Given this list of marker genes ARRDC1, STAM, SDCBP, ATP9A, ARRDC4, CHMP2A, HGS, SNF8, RAB7A, ATP13A2, CHMP3, TSG101, SMPD3, SDC4, CD34, PRKN, PDCD6IP, SDC1, CHMP6, VPS4A, RAB11A, IFNG, RAB27A, VPS4B, COPS5, here is a description of the gene set: The assembly and secretion a set of components to form an extracellular vesicule, a membrane-bounded vesicle that is released into the extracellular region. Extracellular vesicles include exosomes, microvesicles and apoptotic bodies, based on the mechanism by which they are released from cells and differentiated based on their size and content. species: Homo sapiens Human Gene Set: GOBP_EXTRACELLULAR_VESICLE_BIOGENESIS